The following is a description of a gene set: The movement of a cell along the process of a radial glial cell involved in cerebral cortex glial-mediated radial migration. Mouse Gene Set: GOBP_CELL_MOTILITY_INVOLVED_IN_CEREBRAL_CORTEX_RADIAL_GLIA_GUIDED_MIGRATION studied in species Mus musculus, and this is the list of marker genes: Sun2, Syne2, Sun1, Srgap2, Dab2ip, Bmerb1